Given this list of marker genes MKI67, NQO1, CDC45, DCK, TOPBP1, IMPDH2, ABCA1, CKS2, CKS1B, DNMT1, TCF19, NCAPH, IL13RA1, CDCA8, RFC5, AQP1, CDC7, H2AC4, CSRP2, TYMS, RAD51AP1, NASP, CDK1, MCM3, USP1, TK1 (thymidine kinase 1), RRM1, TACC3, PLK1, MCM2, MNDA, TOP2A, LMO4, DTYMK, CCNE2 (cyclin E2), MCM4, FEN1, CDCA7 (cell division cycle associated 7), RACGAP1, PCNA, CSTF2, CENPK, CCNF, LRP5, KIF22, NUP85, CDC20, GAS6, KIF11, VCAN (versican), PCLAF, DLGAP5, TTK, HMGB2, KPNA2, KIF4A, PNP, POLA1, E2F8, ASF1B, CX3CL1, BZW1, MCM5, KIF20A, ADAM8, AURKA, KIF2C, RNASEH2C, ILF2, FIGNL1, MCM7, CCNB2, CCNB1, MCM10, TFDP1, CD4 (CD4 molecule), SMC2, BUB1, SLCO3A1, TUBB6, SLBP, HELLS, RRM2, NUSAP1 (NCBI Gene Id 82534), HGF, ATF6B, CDC6, BRCA1, EZH2, PRIM1, PTGFR, RAD51, MAD2L1, MAN2A1, PRC1, KLF5, DTL, BIRC5, INCENP, OSMR, WNT4, here is a description of the gene set: from publication Burton GR, Nagarajan R, Peterson CA, McGehee RE Jr (PMID 15033539) During cellular differentiation and development, it is recognized that many complex molecular mechanisms as well as precise patterns of differentially expressed genes occur in directing precursor cells toward a given lineage. Using microarray-based technology, we examined gene expression across the course of 3T3-L1 adipocyte differentiation. Total cellular RNA was isolated at times 0, 2, 8, 16, 24, 48, and 96 h following treatment with either standard hormonal inducers of differentiation; insulin, dexamethasone, isobutylmethylxanthine (IDX), or IDX plus trichostatin A (TsA), a histone deacetylase inhibitor and potent adipogenic inhibitor. cRNA was synthesized from cellular RNA and hybridized to high density Affymetrix MG_U74Av2 microarray gene chips containing 12,488 cDNA/Expressed Sequence Tags (ESTs) probe sets. From the IDX-only treated cells, all probe sets that were either unchanged or differentially expressed less than 2-fold throughout differentiation with respect to time 0 preadipocytes were excluded from further analyses. This selection resulted in a net of 1686 transcripts, 859 were increased in expression, and 827 were decreased in expression at least 2-fold across differentiation. To focus in on genes that were more specific to differentiation, the same analysis was performed on IDX plus TsA-treated non-differentiating cells and all probe sets from the IDX-only group that exhibited similar expression profiles in the non-differentiating TsA-treated group were excluded leaving a total of 1016 transcripts that were regulated only under differentiating conditions. Six hundred and thirty-six of these transcripts were elevated at least 2-fold and 380 exhibited a decrease in expression relative to time 0 preadipocytes. This group of genes was further analyzed using hierarchical clustering and self-organizing maps and resulted in the identification of numerous genes not previously known to be regulated during adipocyte differentiation. Many of these genes may well represent novel adipogenic mediators and markers of adipogenesis. Strongly up-regulated at 16-24 h during differentiation of 3T3-L1 cells (fibroblast) into adipocytes. species: Mus musculus Human Gene Set: BURTON_ADIPOGENESIS_3